The following is a description of a gene set: Reactome Pathway: Presynaptic nicotinic acetylcholine receptors This event has been computationally inferred from an event that has been demonstrated in another species.<p>The inference is based on the homology mapping from PANTHER. Briefly, reactions for which all involved PhysicalEntities (in input, output and catalyst) have a mapped orthologue/paralogue (for complexes at least 75% of components must have a mapping) are inferred to the other species. part of: Acetylcholine binding and downstream events species: Mus musculus electronically inferred by orthology from the curated human pathway, and this is the list of marker genes: Chrna4, Chrne, Chrnb2